The following is a description of a gene set: species: Mus musculus Growth hormone receptor signaling Mouse Gene Set: REACTOME_GROWTH_HORMONE_RECEPTOR_SIGNALING, and this is the list of marker genes: Ptpn1, Prl, Sh2b1, Prlr, Stat5b, Stat5a, Lyn, Jak2, Gh, Mapk1 (mitogen-activated protein kinase 1), Ghr, Mapk3